The following is a description of a gene set: studied in species Homo sapiens Glycolysis and gluconeogenesis Human Gene Set: WP_GLYCOLYSIS_AND_GLUCONEOGENESIS, and this is the list of marker genes: ENO2, MPC1, PKM, HK1 (hexokinase 1), PFKM, PDHA1, MDH2, LDHA, MDH1, ENO3, MPC2, HK2, PFKL, PGAM1, DLAT, SLC2A1, ALDOB, SLC2A2, G6PC1, ENO1, GOT2, ALDOC, PKLR, GPI (NCBI Gene Id 2821), GCK, PCK1, PFKP (NCBI Gene Id 5214), FBP2, SLC2A3, DLD, ALDOA, PGK2, HK3, LDHAL6B, PGK1, PC, GOT1, SLC2A5, TPI1 (triosephosphate isomerase 1), SLC2A4, GAPDH, LDHC, FBP1, LDHB, PGAM2